Given this list of marker genes ANKFY1, VPS26A, TBC1D5, DCTN1, SNX3, RAB7A, MAGEL2, VPS29, ENTR1 (endosome associated trafficking regulator 1), VPS26B, SNX12, VPS35, SNX1 (sorting nexin 1), SNX8, TRIM27, SNX27, SNX5, SNX6, DENND4C, DENND5A, SNX2, here is a description of the gene set: studied in species Homo sapiens Human Gene Set: GOCC_RETROMER_COMPLEX A conserved hetero-pentameric membrane-associated complex involved in retrograde transport from endosomes to the Golgi apparatus. The budding yeast retromer comprises Vps35p, Vps29p, Vps26p, Vps5p, and Vps17p. The mammalian complex shows slight variation in composition compared to yeast, and comprises SNX1 or SNX2, SNX5 or SNX6, VPS26A or VPS26B, VPS29, and VPS35.